The following is a description of a gene set: Genes predicted to be targets of miRBase v22 microRNA mmu_miR_6369 in miRDB v6.0 with MirTarget v4 prediction scores > 80 (high confidence targets). from publication Chen Y, Wang X (PMID 31504780) species: Mus musculus Mouse Gene Set: MIR_6369, and this is the list of marker genes: B4gat1, Bcl2l11, H2ax (NCBI Gene Id 15270), Mrc2, Kcnk2, Zfp980, Nlk, Sphkap, Gad1, Sptlc2, Mapk14, Gfer, Camk2b, Tor2a, Cyb561d1, Ccdc25, C1ra, Nemp1, Dock3, Kbtbd6, Dhx33, Zxdc, Zcchc14, Ipcef1, Map6d1, Igfbp4, Dlc1, Tfcp2l1, Gnao1 (guanine nucleotide binding protein, alpha O), Il1r1, Prss44, Dmrtb1, Rbm3, Polr3d, Appl2, Rapgef2, Sesn1, 2510009E07Rik, Cdh7, Lrsam1, Rnf2, Vstm4, Gfpt1, Crat, Foxred2 (FAD-dependent oxidoreductase domain containing 2), Zswim7, Laptm4b, Klhl1, Taok1 (TAO kinase 1), Spon1, Dlgap4, Tceanc2, Kif3b, Rasa1, Rc3h2, Dusp8, Tada2b, Pla2g4e, Ube2k, Skida1, Als2, Mecp2, Agps, Gal3st2c, Ebf2, Stc2, Bco1, Slc16a2, Grik3, Matr3, Nfxl1, Fyb2, Dusp16, Zfp947, Gorab, Zfp942, Kctd21, Mboat7, Cmtm4, Tmem164, Mboat1, Stx5a, Prdm1, Midn, Iffo2, Depdc5, Ptger4, Kbtbd13, 3110082J24Rik, Rex2, Sting1, Neurod1, Zfp975, Fam210b, Stradb, Sema4b, 2810459M11Rik, Zfp981, Ska3, Trim66, Entpd6, Rnf41, Rala, Fsd1l, Diaph1, Kcnb1, Hnf1b, Rap2c, Trp53bp1, Arid5a (NCBI Gene Id 214855), Zfp68, Tmem121b, Cited4, Rps15a, Slc25a44 (NCBI Gene Id 229517), Zfp811, Nup210, Samd4b, Tmem70, Gal3st3, Slc25a25 (NCBI Gene Id 68663), Cdk16, Plcl2, Pkdcc, Pde1a, Apob, Mau2, Atp13a2, Fgf11, Zfp654, Gm11545, C1qtnf1, Aldh5a1, Abcb9, Lmbr1l, Avl9, Magi1, 9930012K11Rik, Dmtn, Nadk2, Nova2 (NCBI Gene Id 434131), Tbc1d24, Trpm1, N4bp1, Tmem267, Tmed8, Cdkn1b, Xpo7, Otud5, Ranbp10, Rubcn, Bhlhe22, Brd8, Insig1, Ark2c, Atad2b, Pdgfra, Mxi1, Anks1, Cnot6, Tmem245, Dgkk, Med13, Kcnip1, Chd5, B3gnt5, Pigm, Ppp1r16b, Chmp1b2, Per2, Mia3, Rap1b, Pik3cg, Klhdc9, Mrpl45, Snap91, Ago4, Snn, Add2, Rmi1, Zfp446, Ntsr1, Zbtb37, Spast, Klf8, Mbd6, Fam78b, Rab8a (RAB8A, member RAS oncogene family), Nlrp6, Tspan14, Reep1, Dyrk2, Zxdb, Sdf2, Vav2, Fst, Hspb7, Kptn, Rap1a, Klrb1a, Ptprf, Rnf138 (NCBI Gene Id 80618), Ttc17, Nefm, Sema4a, Tpmt, Amotl2, Oxtr, Pigv (phosphatidylinositol glycan anchor biosynthesis, class V), Nav2, Sstr1, Ago3, Agpat1, Blzf1, Calhm4 (calcium homeostasis modulator family member 4), Ndst1, Lhpp, Med8, Zfp697 (zinc finger protein 697), Wnt8b, Tmem161b, Tcf7, Snhg11, Sncaip, Calcr, Rasal1 (RAS protein activator like 1 (GAP1 like)), Nrp2, Nphp1, Smagp, Mydgf, Sart1, Pskh1, Klk10, Lsamp, Lmtk2 (lemur tyrosine kinase 2), Ncl, Crebl2, Pgap4, Gbx2, Btaf1, Gpr151, Scml2, Luc7l, Abhd13, G6pdx, Grip1, Cers3, Polr1e, Per1, Top1, Dagla, Pml, Zfp820, Rmi2, Zfp600, Amz1, Vgll3, Apba1, Ugcg, Mix23, Clcn3, Plod2